Given this list of marker genes Ccdc15, Wdr90, C2cd3, Cep295, Poc1b, Poc5, Ppp1r35 (protein phosphatase 1, regulatory subunit 35), Cenpj, Chmp2a, Cep120, Vps4b, here is a description of the gene set: studied in species Mus musculus The centrosome organization process by which a centriole increases in length as part of the process of replication. Mouse Gene Set: GOBP_CENTRIOLE_ELONGATION